The following is a description of a gene set: from publication Schaefer CF, Anthony K, Krupa S, Buchoff J, Day M, Hannay T, Buetow KH (PMID 18832364) Human Gene Set: PID_CDC42_REG_PATHWAY Regulation of CDC42 activity species: Homo sapiens, and this is the list of marker genes: NME1, FARP2, SPATA13, ARHGEF6, PLCG1, DOCK10, ARHGAP17, CDC42, VAV2, ARHGEF7, ARHGEF25, MCF2, MCF2L, DOCK11, RALBP1, DOCK9, GIT1, BCAR3, ITSN2, RACGAP1, VAV3 (vav guanine nucleotide exchange factor 3), ITSN1, NGEF (neuronal guanine nucleotide exchange factor), ARHGDIA, DNMBP, ARHGEF9, APC, FGD1, DOCK6, ARHGAP1